Given this list of marker genes UBE2L5, TIAL1, LRRC37B, ARHGAP6, FAM120B, LCNL1, PXK, PEAR1, LINC02953, MIR4530, MTFMT, MEF2C-AS1, RHOF, SRRM2, CEACAM16-AS1, RCN2, PROSER2-AS1, DLL1, TMEM91, PHF23, TUBA1C, PDE8A, SCYL1, AUTS2, SLC2A1-DT, ECD, PCNX1, TMEM132D-AS1, ATP8B3, PRSS8, MAP3K8, CMBL (carboxymethylenebutenolidase homolog), ACSF3, MIR4632, CAHM, ETS2, AKNA, DLGAP4, GLIPR1L2, PCGF3, SHISA5, H3-3A, H2BC12, CDYL, SOWAHD, NEXMIF, ARHGEF1, LLGL2, NCOA2, LINC01270, ABCA3, CENPJ, EOLA2-DT, H3C12, NDRG2, SEPTIN8, PLK5, H2BC11, GFY, TKT, ADCK5, ARSA, R3HDM4, CDK13-DT, MIR5093, DOCK7, CSK, TYROBP, LINC02363, APBB2 (amyloid beta precursor protein binding family B member 2), SUCLG2-DT, ETV3, MRC2, GREB1 (growth regulating estrogen receptor binding 1), HIVEP2, ADAMTSL5, DEPDC5, RAP1A, GKAP1, FOSL2, POGK, CACNB3, GABBR1, NCK2, UNC13A (unc-13 homolog A), CCND2, PABIR3, SLC16A3, MYO18A, DBP, ATP4A, POU3F2, FOXP4-AS1, IRF2-DT, LMO4, TSC22D4, TRGV4, CAPN12, KANTR, LARP1B, RAB11FIP2, SLC29A4, DNM1, WHRN, FOXP4, GET4, RCSD1 (RCSD domain containing 1), SPINT1, ERBIN-DT, RSRC1, H2AC13, BCL3, FGFR4, ATXN7L1, GDF11, HDAC11-AS1, ACTN3, LYPD5, ERICH6-AS1, PLIN5, WDR27, DOCK7-DT, TCF7L2, PIP4P2, GRIK5, MARK4, RDH10-AS1, WWC1, HDDC2, RPH3A (NCBI Gene Id 22895), IGLV6-57, PNPLA6, COASY, PALS2, COL6A1, H4C2, KLHL22, DCUN1D4, H2BC8, TLE2, ATXN1, GFI1B, H2AC7, CHCHD6, H2BC17, P2RY6, RPS18, EPB41L1, IREB2, EREG, SNUPN, CA11, VWA8-AS1, LHX2, SNCA, ADGRG1, SEMA4B, CHST12, PDXK, STC2, C6orf120, LINC03047, TMEM119, IRX5, SLC38A10, IRF2, FCHO1, RTN4R, DNAI4, ENSG00000179066, PCBP1-AS1, POMGNT1, NRSN2, H2AC12, TFE3, NHLRC4, MICAL3, GMFG, CEACAM21, NCOA7, MEX3C, SPRY3, ZSCAN5A, TRIM21, LZTS3, PISRT1, SLC38A5 (solute carrier family 38 member 5), H2BC5, NUP155, SRC, H1-5, SMPD4, MAGEA8, HEXIM1, PBX2, ARID1B, TFDP1, GLI3, PPP1R18, HGSNAT, MAD2L1BP, SMG1P2 (NCBI Gene Id 440354), IRF2BP1, SYNJ2, TRGV5, CD99L2, SLC2A1, MAST1, LRRC4B, SLC25A42, SYNCRIP, ARHGAP5, PRR5, IQCD, LINC01138, FKBP4, SALL2, MRPL55, DTX1, BRD3OS, GNAQ, RNPEP, SHOX2, DRAP1, PPDPF, ENSG00000231083, SFMBT1, FAM13A, STX16, FGGY, FBXL19, CDHR3, PIGQ, APRT, CASC2, IQANK1, MIR4767, MSMP, SEPTIN9, GART, DOK4, NRSN2-AS1, IQSEC2, H1-2, ZNF148, SETD1B, LINC00623, TRAPPC9, MEG3, FBRS, LHX6, CCDC85C, SAMD4A, RAPGEFL1, NFIC, MEIS2, PLEKHA4, FOXS1, SLC12A4, ACTN4, USP25, CDYL-AS1, CAPS2, P4HB, RHOC, CRYAB, ZNF467, FOS, IFI30, SLC12A5-AS1, QKI, LINGO1, H1-3, ATXN10, AKT1S1, TSPAN32, ZNF71, H1-10, KSR1, EGFL7, TBC1D1, ANGPTL6, SLC25A6, MATN4, DBN1, RGS10, CCDC136, RER1, EBI3, H2AC8, NCLN, HDAC11, TTYH3, RALA, GRAMD1A, EFHB, ERBIN, MAML3, RB1, SERPINH1, SCN1B (sodium voltage-gated channel beta subunit 1), GTPBP2, RGS9, CORO1A, SPINT1-AS1, ZNF217, ZNF892, NFIX, H1-0, GAD1, ZMYND11, BTN2A3P, AHNAK, FIBCD1, TFAP2A, DCHS2, TMEM164, SMG1, LARP1, H4C3, BRIP1, ENSG00000271551, SPATA2, SPATA13, UPP2, BPTF, LINC01089, LINC02771, APOBEC3G, CHD9NB, EML2, AHDC1, PDE2A, MAILR, ACTN2, SAFB, INTS1, GGT1, DUSP16, MAN1A2, NAE1, FBXO41, SRRM2-AS1, SFXN2, PPP1R14C, NIPAL2, HOMER1, THSD4, HAUS7, RFX3-DT, SULF2, NR4A2, TMCC3, SON, ADCY4, IQUB, TTC39C, TRIM41, STX16-NPEPL1, MEF2C, SCMH1-DT, RARA, VSTM2L, SUCLG2, NOX5, PHLDB1, TNRC18, CDK5RAP2, HSD17B14, PRSS33, METAP1, DRAM1, PTPN4, KPNB1, H2BC13, SAE1, EXPH5, IGF2BP3, ZFAND3-DT, TBC1D9, KDM2B, TMEM132B (NCBI Gene Id 84462), ATXN1-AS1, TNFRSF1B, MAN1C1, SCMH1, MIA3 (MIA SH3 domain ER export factor 3), VGLL4 (NCBI Gene Id 9686), PABIR2 (NCBI Gene Id 159090), ACVR1, TMEM63B, UBE2M, FAM83D, H2AZ1-DT, ALKBH2, SLC39A13, ZFHX2, MBD1, NSG2, H2AC11, SAXO5, MAP3K11, H2BC7, LINC00877 (NCBI Gene Id 285286), DLG4, ARRDC2, BAIAP2, BAIAP2L1, TREX2, KRT10, ZC3H4, LCN8, DEDD, DNMT3B, SLC22A23, FBXL19-AS1, ZDHHC24, H2AC17, PARAIL, ENSG00000274565 (NCBI Gene Id 107985020), TRGV2, ALMS1, ISL2, TRGV3, ADAMTS3 (ADAM metallopeptidase with thrombospondin type 1 motif 3), CAMK2N1, PHYHIP, LINC00544, ALDOA, C11orf68, RPL5P24, ZCCHC24, PHF21A, TRGV7, ZFAND3, ZSCAN5A-AS1, PRSS22, SLC27A1, SP3 (NCBI Gene Id 6670), LINC02773, MIR3143, RB1-DT, FAM53A, CPT1C, MIR4710, NR2F2, SPACA6-AS1, ZNF574, LINC02356, CDK13, BRD7, SPACA6, H2AZ1, INTS3, WWC3, FRY, RASAL1, ABCB9, VILL, BRD2 (bromodomain containing 2), ITGB7, HDGF, MAGEA8-AS1, KMT2B, RCAN3, H1-4, COTL1 (coactosin like F-actin binding protein 1), NLRP7P1, GNL3L, AP1S3, CDK18, IL21R (interleukin 21 receptor), OBSCN, here is a description of the gene set: Human Gene Set: NFXL1_TARGET_GENES from publication Yevshin I, Sharipov R, Kolmykov S, Kondrakhin Y, Kolpakov F (PMID 30445619) studied in species Homo sapiens Genes containing one or more binding sites for (NFXL1) in their promoter regions (TSS -1000,+100 bp) as identified by GTRD version 20.06 ChIP-seq harmonization.